Given this list of marker genes KLK12, EVX1, GABBR2, GLTP, LTBP3, FABP4, ACRV1, RAI2, RUNDC3A, ZBTB18, PDCL, ASCL1, CLEC3B, TSC1 (NCBI Gene Id 7248), KLF2, RABAC1, WASF3, SPARC, SLC7A8, CD14, RPL13, USF2, CYP27A1, ZNF395, MYO9B, FUCA1, CFD, SDS, CLDN7, ANAPC2, RARRES1, TCEAL9, CUX1, TP53TG5, KIF13A, CYBA, ENDOG, GRPR, TNFRSF14, ZNF74, VAT1, TESK2, KIFC3, PPAN, PECAM1, MFSD10, ADD3, FARP1, NAGPA, PKD2L1, TAS2R1, SRRM2, TBXAS1, BEX3 (brain expressed X-linked 3), TMEM8B, LEF1, TPBG, ADORA2B, NAP1L3, HPSE, NOD2, ARHGEF1, VPS51, SRPX, TPRA1, CYTH2, VNN1, HOMER3, EPAS1, NAGLU, SP2, LY86, CA6, PDGFC, DUSP13B, PHLDA1, GPNMB, ATP5F1C, FRAT1 (NCBI Gene Id 10023), DBP, HTRA1, CD9, PPP2R5A (protein phosphatase 2 regulatory subunit B'alpha), ICAM3, RXRA, FGF9, HS3ST1, CLEC11A, RPS6KA2, NUDT3, PEPD, CACNA2D2, PMP22, ASAH1, GRB10, DNAJB2 (DnaJ heat shock protein family (Hsp40) member B2), CHRNA7, DPP4, F11, PLXNC1, MZF1, HS3ST2, DXO, HBA1, ISYNA1, CARTPT, ITGA6, KRT5, S100A8, MXD4, MIF, MAGI2, ABLIM1, SIGIRR, DLG4, DRD2, EMP3, DOC2A, FOXO3, ZNF324, IFNA21, LPA, HSF2, APOE, BASP1, VNN3P, PIK3R2, SPAG1, ALOX5, BICRA, DGCR2, SELENOP, MGAT4B, PLIN2, RNASE1, CHST8, IRF3, SNCA, CD2BP2, GCHFR (GTP cyclohydrolase I feedback regulator), CD180, F13A1, SORL1, AR, TPSAB1, GAGE1, ENTR1 (NCBI Gene Id 10807), SPAG8, RNASEL, FCGRT, EEF1D (NCBI Gene Id 87167), ALDH3A2, MS4A4A, RASGRP2, LGMN, HBA2, PLD3, ZNF117, PYCARD, RPGRIP1, PDE6A, NME3, NPL, POLD1, PLPP3, TNS1, HSD17B14, MMD, ANOS1, CA5A, VLDLR (NCBI Gene Id 7436), NEB, MCOLN1, IRS2, DIDO1, CELSR1, DHRS9, SCAND1, MAPK8IP2, ACP5, HAMP, PTH1R, EHHADH, DAB2 (DAB adaptor protein 2), CNR1, FST, PRKCZ, RTN3 (reticulon 3), RBM17, PDE2A, GDF11, ADGRB3 (adhesion G protein-coupled receptor B3), CDC25B, SLC11A1, NISCH, FAIM2, TIMP2, KCNJ14, NOP53, CER1, GSDME, CES1 (carboxylesterase 1), CHPT1, PPP2R3B, PLA2G4B, CTSK, TSPAN4, MAEA, LRPAP1, MAPK12, CADM1 (NCBI Gene Id 337934), GAS7, CEBPD, ADORA3, CAMKK2, CD99, ARHGAP29, PABPC4, CACFD1, GHR, HMOX1, GPRC5C, GRN, PTDSS2, IMPA2, ACADVL, NR0B1, SGSH, FLRT2, OCA2, HOXC5, DPEP2, BLVRB, FXYD1, SLC43A1, CACNA2D3, MERTK, CHGA, GNB1L, TUBGCP2, FCMR, TENM1, CSF3R, DHRS3, IGF1, PLCB2, LCK, PON2, APOC1, KCNK10, PCYOX1, DNASE2, RAP2A, MAD1L1, IKZF4, APLNR, RNASET2, CXCL2, AVPR1A, CFAP410, CTSD, APOC2, B3GALT4, LRP1, TPST2, SCARB1, CPLX2, TNFRSF1A, GADD45B, CHST3, RNF130, VPREB3, INTS6, ID3, GRID2, GAA, RASAL1, CALCB (NCBI Gene Id 797), TM6SF1, STC1, AGPAT2, GAK, ERF, SLC23A2, HPCAL1, GML, PDK4, here is a description of the gene set: studied in species Homo sapiens from publication García-Piñeres AJ, Hildesheim A, Dodd L, Kemp TJ, Yang J, Fullmer B, Harro C, Lowy DR, Lempicki RA, Pinto LA (PMID 19155521) Genes down-regulated in peripheral blood mononuclear cell 2m vs 0m in young adults (18-25) after exposure to HPV-16 L1 VLP, time point 2M. Comment: Gene Expression with Neutralizing Antibody Levels Human papillomavirus (HPV) virus-like particle (VLP) vaccines were recently licensed. Although neutralizing Ab titers are thought to be the main effectors of protection against infection, early predictors of long-term efficacy are not yet defined and a comprehensive understanding of innate and adaptive immune responses to vaccination is still lacking. Here, microarrays were used to compare the gene expression signature in HPV-16 L1 VLP-stimulated PBMCs from 17 vaccine and 4 placebo recipients before vaccination and 1 mo after receiving the second immunization. Vaccination with a monovalent HPV-16 L1 VLP vaccine was associated with modulation of genes involved in the inflammatory/defense response, cytokine, IFN, and cell cycle pathways in VLP-stimulated PBMCs. Additionally, there was up-regulation of probesets associated with cytotoxic (GZMB, TNFSF10) and regulatory (INDO, CTLA4) activities. The strongest correlations with neutralizing Ab titers were found for cyclin D2 (CCND2) and galectin (LGALS2). Twenty-two differentially expressed probesets were selected for confirmation by RT-PCR in an independent sample set. Agreement with microarray data was seen for more than two-thirds of these probesets. Up-regulation of immune/defense response genes by HPV-16 L1 VLP, in particular, IFN-induced genes, was observed in PBMCs collected before vaccination, with many of these genes being further induced following vaccination. In conclusion, we identified important innate and adaptive response-related genes induced by vaccination with HPV-16 L1 VLP. Further studies are needed to identify gene expression signatures of immunogenicity and long-term protection with potential utility in prediction of long-term HPV vaccination outcomes in clinical trials. Human Gene Set: GARCIA_PINERES_PBMC_HPV_16_L1_VLP_AGE_18_25YO_2MO_DN